The following is a description of a gene set: studied in species Homo sapiens from publication Yamagata T, Benoist C, Mathis D (PMID 16623764) Genes down-regulated in T cells: CD8A versus CD8A CD8B. Human Gene Set: GSE3039_ALPHAALPHA_VS_ALPHABETA_CD8_TCELL_DN Three innate (B1-B, NKT, CD8aaT cells) and adaptive (B2-B, CD4T, CD8abT cells) cell-types were sorted by FACS. Three biological replicates for NKT, CD4T, CD8aaT, CD8abT cells and two biological replicates for B1 and B2 cells were generated and the expression profiles were determined using Affymetrix Mu74Av2 chip. Comparisons between the sample groups allow the identification of genes differentially expressed between the innate and adaptive cell-types., and this is the list of marker genes: MEPCE, PLPBP, PPP1R14A, PTPRC, SNUPN, PLXNC1, FCMR, UBAC2, ST6GALNAC2, VPREB3, SLC25A37, SLC46A3, ALDH1A1, HLA-DOA, CD300LB (CD300 molecule like family member b), NIPAL3, E2F2, NHSL2, XPC, NR1H3, TNFRSF17, C2, PRG2, HPGD, PTP4A3, LRCH3, TSPAN2, SEPTIN6, ARPC5L, FAM32A, GNGT2, ITGA4, TXK, STX16, EBF1, EPX, PPP1R12A, LCK, ABCA3, EVA1A, FBRSL1, AP1S3, PNPO, SLC25A33, FOXP1, DBNL, SPIC, FLT3, HLA-DOB, LAX1, ZNF710, HEG1, ARHGAP39, TRIM7, FCRL1, PPTC7, P2RX1, RAB30, TRAF2, ASB2, ATAD2B, MARCO (macrophage receptor with collagenous structure), GLCCI1, PLPP1, INPP5F, ZNF565, HAP1, ICAM2, CHMP1B, CXCR5 (NCBI Gene Id 643), KIF9, CD7, NCR1, GATA1, NXPE3, MED12, IRF4, SLCO5A1, MBP, SERF2, BCL11A, CTNND2, ROCK1, GP2, TNFRSF13C, BACH1, KNOP1, PGLYRP2, CTSW, MDM4, HCK, ITPR1, AP1M1, CR2, HEMGN, ADGRA2, BPGM, KCNJ16, CD5, CDH17, RAPGEF1, S1PR5, RASGRF2, PXN, PIP4K2A, DNAJC8, IGHM, PDE8B, PLA2G2D, CREG1, GIMAP6, TRIM10, SNX31, SERPINB7, RYR3, CA1, TESC, PLEKHM3, NSD1, PHETA2, CREB1, LCOR, SPIB, DNAJC7, CYB5R1, ABCB4, CXCL12, RASGRP3, SPN, GOSR2, GZMA (NCBI Gene Id 3001), SLC18A2, ROGDI, COCH (cochlin), CD79A, TMEM178A, NKG7, RHAG, CALHM2, CD28, VSTM4, GIMAP4, ANP32A, PIGL, VAV2, MZB1, CD79B, SLC15A2, TBX21, PTGER3, SYTL1, SLC45A3, PSIP1, APOC1, ENTPD6, KLRC1, IL5RA, PTGIR, SCAP (NCBI Gene Id 22937), ADRB1, GPR174, GPR18, ARHGAP17, MERTK, SNX25, FYB1, PPM1K, C2CD5, IKZF3, FCN1, SFI1 (SFI1 centrin binding protein), PRICKLE2, HPS3, CD2, ZBTB9, CD4, ADAM23, KIAA0930, RAB39A (NCBI Gene Id 54734), AHSP, OTUB2, MYCL, STK10, BTLA, STAB2, NFKB1, TMCC2, TSPAN33, AKAP10, CCR3, CMBL, FASLG, TRIM5, SUOX, DPP4, IVD, OMA1, PRG3, TENT5A, CD3G